The following is a description of a gene set: part of: RHO GTPase Effectors electronically inferred by orthology from the curated human pathway Reactome Pathway: RHO GTPases Activate WASPs and WAVEs species: Mus musculus This event has been computationally inferred from an event that has been demonstrated in another species.<p>The inference is based on the homology mapping from PANTHER. Briefly, reactions for which all involved PhysicalEntities (in input, output and catalyst) have a mapped orthologue/paralogue (for complexes at least 75% of components must have a mapping) are inferred to the other species., and this is the list of marker genes: Actr2, Arpc4, Wasf1, Actr3 (ARP3 actin-related protein 3), Cdc42, Wasf3, Arpc5, Ptk2, Nckipsd, Cyfip2, Mapk3, Grb2, Arpc2